Given this list of marker genes DNAJB12, KLF6, TCIM, HSD11B1, EPB41L5, SBNO1, BCL9, HNRNPA2B1, PPP4R2, CPNE5, PCSK5, SCN8A, NRXN1, SENP2, EP300, SUSD5 (sushi domain containing 5), CLMN, C5, ETS1, ASPH, SSBP2, CEP97, SLC4A7 (NCBI Gene Id 9497), C4orf33, ENAH, USP9X, STOX2, EID1, CPEB4, PCDH7, BBS12, AJUBA, TSC22D2, SMG9, ZNF138, CLEC1A, SRBD1, WDFY3, CACNA2D3, RBFOX2, RNF6, RCHY1, E2F3, SLA, SEMA6D, ARF6, LRRN4CL, PIK3CA, RNF144A, RNF2, POC1B, PXYLP1, MAP4K4, TMEM25, SLC6A2, MYT1L, KLF7, PLS1, CAV1, MYOT, here is a description of the gene set: Human Gene Set: MIR6797_3P Genes predicted to be targets of miRBase v22 microRNA hsa-miR-6797-3p in miRDB v6.0 with MirTarget v4 prediction scores > 80 (high confidence targets). studied in species Homo sapiens from publication Chen Y, Wang X (PMID 31504780)